Given this list of marker genes UBE4B, RERE, NDN, CTNNB1, MEN1, SKI, PDPN, KCNJ11, LEP, ALMS1, UBE3A (ubiquitin protein ligase E3A), PRKCZ, ADCY3, NTRK2, HNF1A, SETD2, BSCL2, ADNP, ABCC8, PWAR1, LUZP1, SLC2A3, PREPL, BBS9, AGPAT2, CASZ1, HSPG2, GABRD, ITPR3, SRRM2, TRANK1, MAGEL2, YY1 (NCBI Gene Id 7528), GNAS, PWRN1, HERC2, MKRN3, PTPN22, OCA2, MYT1L, IFT74, SNRPN, GPR101, EZH2, PSEN1, MMP23B, UCP2, ATP5F1B, SLC5A2, GRN, SIM1, MN1, HTT, PRDM16, MAPT, RFX7, SLC3A1, MBD5, POMC, SATB2, ACBD6, NPAP1, MAN1B1, MC4R, SUPT16H, SPEN, LEPR, SNORD115-1, BRAF (NCBI Gene Id 673), ATP10A, CHD8 (chromodomain helicase DNA binding protein 8), SH2B1, IL6 (NCBI Gene Id 3569), OFD1, ZFX, SNORD116-1, KCNAB2, PCSK1, here is a description of the gene set: species: Homo sapiens Human Gene Set: HP_POLYPHAGIA A neurological anomaly with gross overeating associated with an abnormally strong desire or need to eat. Polyphagia